The following is a description of a gene set: Mouse Gene Set: GOBP_MICROTUBULE_BASED_PROTEIN_TRANSPORT studied in species Mus musculus A microtubule-based process that results in the transport of proteins., and this is the list of marker genes: Camsap3, Kif1a, Kif5a, Map1a, Mapk8ip3, Kif5c, Clip3, Dlg2, Cep131, Hspb1, Neto1, Kif3a, Rab27b, Kif5b, Myo5a, Spag17